Given this list of marker genes DNAAF1, RSPH1, RSPH4A, DNAAF11, DNAAF3, RSPH3, CFAP300, CFAP298, TTC12, ZMYND10, DNAAF4, DNAI1, DNAAF5, here is a description of the gene set: Immotile cilia species: Homo sapiens Human Gene Set: HP_IMMOTILE_CILIA